The following is a description of a gene set: Mouse Gene Set: GOBP_IMMUNE_EFFECTOR_PROCESS Any process of the immune system that executes a component of an immune response. An effector immune process takes place after its activation. species: Mus musculus, and this is the list of marker genes: H2-M10.2, Kif5b, Dnase1l3, Ighv5-12, Ighv8-8, Ifna12, Ufl1, Klrc3, Ighv1-22 (NCBI Gene Id 780883), Scimp, Mir181b-1, Pnp, BC037156, Fcgr3, Il6, Il1b, Il2rg, Ighv4-1, Abr, Xrcc4, Ccl19, Lgals3, Gab2, Ighv2-9-1, Cd22, Notch2, H2-Q6, Il4ra, Tlr7, Itgam, Ifna14 (interferon alpha 14), Mbl1, Emp2, Gimap3, Ighv11-2, Ccl20, Foxf1, Smad7, H2-Q1, Klre1, H2-T24, Stat6, Ptx3, Cfb (NCBI Gene Id 14962), Cd96, Ighv10-1, Slamf8, Ighv8-2, Cgas, C8g, Trp53, Selenok, Cxcl1, Gkn2, Cdh17, Lgals8, Ncf1, Tmbim6, Slamf6, H2-T22, Stx4a, Pck1, Nkx2-3, Lypd10, Tlr9, Ighv1-81, Sirt1, Casp4, Ighv1-54, Irak4, Lipa, Ffar2, Angpt1, Cd160, Mtor, Nlrp6 (NCBI Gene Id 101613), Sbno2, Cfhr2, H2-Q4, Rag2, H2-Q2, Vamp8, Ighv5-9, Ighv8-9, Crk, Gcnt3, H2-M10.5, Msh2, Ighv14-3, Ighg2c, Tap1, Ighv9-3, Pram1, Ighv5-16, Gata3, Eomes, Mir301, Foxj1, Lyst (NCBI Gene Id 217998), Wdr1, Mrgprb1, Spon2, Syk (spleen tyrosine kinase), Colec11, Pirb, Gzmm, Inava, Klri1, Eif2ak4, Myo1f, Casp1, Cd80, Coro1a, A2m, Shb, Cr2, H2-M11, C1qbp, Ighv2-7, Il13ra2, Ifna5, Cd8a, Nsd2, Bcl3, Appl1 (NCBI Gene Id 97938), Ighv1-4, Btk, Dock11, Ighv8-13, Ighv16-1, Lep, Snx4, Mad2l2 (MAD2 mitotic arrest deficient-like 2), Pik3cb, Ifna7, Prdx1, Ighv1-63, C2, Gm13283, Fosl2, Men1, Ighv1-76, Ighv8-4, Ighv1-5, Nkg7, Cd55b, Hmox1, Tgfb1, St3gal1, Dusp22, Dbh, Trex1, Xbp1, Psen1 (NCBI Gene Id 19164), Traf2, Klk5, Ddrgk1, Il2rb, Clec12b, Irf1, Ighv3-1 (NCBI Gene Id 780803), Klrc2, Mapkapk2, Ighv6-7, Klhl22, F2rl1, Il17f, Gba1, Dlg1, Nfkbid, Ighv5-17, H2-DMa, Trp53bp1, Cd19, Ccl2, Shld3, Jak3, H2-M5 (NCBI Gene Id 630349), Ceacam1, Ighv6-3 (NCBI Gene Id 675759), Nfkbiz, Ifna16, 6030468B19Rik, H2-T5, Ager, Iglc2, Stat5a, Itgb8, Rc3h1, Lyn, Map3k7, Il1r1, Mir873a, Ighe, Raet1d, C1qb, Serpinb9d, Il9, Itfg2, Cd177, Il2, Pgc, Cplx2, Tlr3, Ighv1-47, Foxp3, Ighv1-11, Pla2g5 (phospholipase A2, group V), Cd36, Ighv1-16, Ifnb1, Irak3, Clec7a, C1s2, Klrk1, Ephb6, Fzd5, Vav1, Batf (NCBI Gene Id 54359), Swap70, C8b, Ighv5-12-4, Nectin4, Scnn1b, C9, Tlr4 (NCBI Gene Id 21898), Cd55, Hspd1, Rab44, Hprt1, Rigi, C1qa, Bcl6, Il20rb, Ighv1-82, Plcg2, C7, D6Wsu163e, Enpp3, Hpx, Ighv6-5, F2, Fbxo38, Colec10, Stap1, Jag1, Psen2, Ighv8-5, Cd69, Rorc, H2-D1, Lilrb4a, Rnf168, Clec4d, Wnt5a, Adora2b, Tnf, Ripk3, Cd244a, Il21, Kmt5b, Ighv2-2, Exosc3, Dhx36, Itgb2l, Sema4a, Rora, Igll1, Cd59a, Ptpn22, Tyrobp, Myb, Pik3r6, Ifna1, Cd37, Irf7, Foxp1, Cebpg, Ctsc, Klrb1f, Card9, Rps6, Fer, Pcyox1l, Ulbp1, Ebag9, Kdelr1, Cfhr4, Ighv1-49, Otud5, Rara, Nckap1l, Fcer2a, Tnfsf18, Ighv5-4, Ung, Icosl, Stx11, Plec, Prdx2, Ighv7-1, Ighg2b, Ighv2-3, Pglyrp4, Dusp10, Ifna11, Ighv1-66, Xcl1, Ighv2-6, Gfer, Sash3, Fes, Ighv2-9 (NCBI Gene Id 640046), Tnfsf13, Stxbp1, Mdk, Parp3, Ptgdr, Ndst2, Ighv9-4, Pou2f2, Slc15a4, Tril, Ddx60, Ifnz, Pld2, Hlx, Fcna, 2410137M14Rik, Rab27a, Fcgr1, Ifna9, Serpinb9e, Apoa2, Twist2, Ptpn6, Ahr, Ighv3-3, Ighv1-55, Pou2af1, Dhx58, Tek, Cybc1, Azgp1, Nlrx1, Tnfaip3, Ddx21, Sh2d1b2, Tac4, Ighv3-8 (immunoglobulin heavy variable V3-8), Atg9a, Ighv1-26, Fcgr4, Vpreb3, Gm13276, Laptm5, Ighv1-31, Ube2j1, Zp3r, Cfhr1, Fcmr, Hmces, Calhm6, Enpp1, Ighv1-34, Plxna1, Stard7, H2-Ea, Irf4, Slc11a1, Cd40, Cd180, Klrb1b, Cd1d2, Anxa3, Rtn4, Lcp1, Jagn1, Fcgr2b, Serping1, C1rb, Cfp, Ifng, Crhr1, Crlf2, Il18r1, Apoa1, Ighv2-5, Ace, Tusc2, Zfp683, C1rl (complement component 1, r subcomponent-like), Msh6, Gprc5b, Fcer1g, Ddx1, Ighv2-4, Lat, Bcl10, Nlrp3, Ulbp3, Cd47 (NCBI Gene Id 78539), Traf3ip2, Ndfip1, Mavs (NCBI Gene Id 228607), Trpm4, Fut7 (fucosyltransferase 7, NCBI Gene Id 99110), Ms4a2, Sema6d, Ighv1-84, Krt1, Cd226, Lat2, Pkp3, Elane, Gata1, Paxip1, Ighv1-43, H2-DMb1, Ptk2b, Ccr6, Csf2rb2, Abl1, Ighm, H2-M9, Klrb1, Pms2, Acp5, Pcyt1a, Tirap, Arg1, Hmgb1 (high mobility group box 1), Gpr15lg, Rasgrp4, Tcim, Il13, Ighv3-6, Ifnk, Ywhaz, H2-M2, Iglc3, Gzmb, Fas, Irf5, H2-M3, Rgcc, Vsig4, Cd46, Rac2, Sanbr (NCBI Gene Id 71675), Il27ra, Bst2, Twist1, Ptprc, Inpp5d, Spn, Lig4, Ighv1-67, Lamp1, Ighv14-4, Lilrb4b, Lgals9 (lectin, galactose binding, soluble 9), Il23r, Trim6, Scn11a (sodium channel, voltage-gated, type XI, alpha), Dock2, P2rx7, Igha, Supt6, Ighg3, Ripk2, Gm13277, Epx, Clec2d, Il9r, Cfh, Igf2, Ighv1-15, Clec4g (C-type lectin domain family 4, member g), Atp7a, Crtam, Lbp, Cd24a, Vamp2, Havcr2, Gimap5, Pglyrp1, Evpl, Ighv1-58, Lef1, Prkaa1, H2-M10.4, Phb1, H2-M1, Ighv6-6, H2-M10.3, Cd5l, Il4i1 (NCBI Gene Id 15088), Ighv9-1, Sphk2, Ada, Gm13272, Muc4, Mlh1 (NCBI Gene Id 68687), Il25, Vsir, Cd300a, Serpinb9h, Loxl3, Cxcl5, Rc3h2, Serpinb9, Irf8, Spi1, Shld1, Ighv1-7, Atad5, Pikfyve, Clu, H2-M10.1, Il31ra, Nppa, Lacc1, Ppp3cb, Tmem98, Masp2, Il23a, Zp3, Il12a, Hc, Gm13275, Rif1, Stxbp3 (syntaxin binding protein 3), Tnfrsf4, Gbf1, H2-T15, Susd4, Hcst, Stat4, H2-T13, Klrh1, Unc93b1, Slc22a13, Ffar3 (free fatty acid receptor 3), Ncr3-ps, Cd2, Nod1, Cd27, Rasgrp1, Traf6, Dnajb9, Lfng, Tsc1, Pla2g3, Cbl, Panx1, Rftn1, Cd28, Galnt2, Trem2, C8a, S100a9, Ascl2, Ighv1-78, Serpinb9g, Rbp4, Ep300, Ctsg, Kmt2a, Fcer1a, Myd88, Itm2a, Arrb2, Tap2, Serpinb9b, Lta, Phf14, App, Ighv2-6-8, Clec4e, Lag3, Atg5, Cd70, Tgfb3, Treml4, Kit, Il17a, H2-DMb2, Cr1l, Cd86, Dennd1b, Ighv3-5, Kctd9, Ighv9-2, Ephb2, Zpbp2, Ly9, Sh2d1b1, Tnfrsf14, Ccl3, Stx7, Mr1, Malt1 (NCBI Gene Id 240354), H2-K1, Kmt2e, Slamf1, C1s1, Nectin2 (nectin cell adhesion molecule 2), Cyrib, Kars1, Plcl2 (phospholipase C-like 2), Slc18a2, Prkdc, Cd81, Apbb1ip, Masp1, H2-M10.6 (NCBI Gene Id 399549), C1ra, Mill1, Il13ra1, Ighv1-39, Ighv1-56, Ighv14-1, Rsad2, Klrd1, Was, Lypd11, Ighg1, Csf2rb, Bcr, Litaf, Fgl2, Ighd, Sema7a (sema domain, immunoglobulin domain (Ig), and GPI membrane anchor, (semaphorin) 7A), Gata2, Pi4k2a, H60c, H60b, Rnf19b, Prkce, Cd59b, Milr1, Unc13d, Gzmn, Mrgprx2, Mfng, Tlr2, Ivl, Nos2, Kmt5c, Pomc, Anxa1, Cracr2a, Klrb1a, Dao, Arid5a, Pycard, Siglecg, Ins2, Lgals1, Clcf1, Entpd7, Ighv1-23, Gapt (Grb2-binding adaptor, transmembrane), Gzmc, Snap23, Ins1, Ighv1-42, Itgb2, Ighv1-75, Sftpd (NCBI Gene Id 20390), Ifne, Ccr7, H2-Q10, H2-T3, Zfp35, Iglc1, H2-T23, Pdpk1, Mzb1, Ighv10-3, Slamf9, Pagr1a, Phb2, Prkcd, Ifna4, Ighv7-3, Hspa8, Lrp1, Ighv1-85, Ifnab, Icam1, Gm13271, Pf4, Ighv12-3, Ighv14-2, Ifna15 (NCBI Gene Id 242517), Grn, Prg2, Chga, Pvr, Stat5b (signal transducer and activator of transcription 5B), Brd2, Sh2d1a, Sucnr1, Mir181b-2, Brd4, Mir326, Ccr2, Myo18a, H2-Q7, Ptger4, Ifna2, Aire, Socs5, Ighv1-71, Klk7, Gadd45g, C1qc, Serpinb9c, Itgal, Cfi, C4a, Stat3, Aicda, Ankrd17, Tnfrsf1b, Raet1e, Plekhm2 (pleckstrin homology domain containing, family M (with RUN domain) member 2), Klrc1, Tbk1, Nbn, Crp, Stxbp2, Ighv1-24, Htr2a, Ppl, Aplf, Mif, Il6ra, Pglyrp2, Tbx21, Ptgds, Ighv8-12, Il4, Pglyrp3, Ighv1-61, Axl, Cfd, Pik3r1, Rabgef1, Exo1, Ywhag, Ighv6-4 (NCBI Gene Id 636744), C4bp, Nod2, Clnk, Hk1, Dysf, Ighv1-50, Ighv11-1, Tgfb2, Ifna6, Gfus, Ighv1-72, Mir324, Tnfsf4, Cd274, Rps19, Usp17le, Trem3, Ifna13, Abcc1, Itgb6, Mbl2, Pkn1, Muc19, Arl8b, Trem1 (triggering receptor expressed on myeloid cells 1), Gpr183, Zc3h12a, Nppc, Nmi, Dnase1, Ptafr, Kdm5d, Il7r, C4b, Fadd, Zbtb1 (zinc finger and BTB domain containing 1), Gpi1, C3, B2m, Cadm1, Fgr, Fcrlb, Cd1d1, Exosc6, Ifi35, Myo1g, Tfrc, Ighv8-6, Il5, Relb, Slfn2, Opa1, Adora3, Cebpb, C6, Ercc1, Dpp4, Cd300lb, Tcirg1, Prkcz, Ighv3-4, Klri2, Hfe, Ighv1-62-3 (NCBI Gene Id 668549), Ighv1-53, Appl2, Mpo, Nr4a3, Cuedc2, Pdcd1, Zbtb7b, Grb2, Dll1, Cd40lg, Ighv13-2, Klrb1c, Cd74, Prf1, Ighv1-77, Il33, Cd84, Ighv5-6, Ticam1, Rnf8, Ighv8-11, Il12b, Psg22, Ighv1-64, Grp (NCBI Gene Id 225642), Ighv1-12, Il18rap (NCBI Gene Id 16174), Il18, Fcnb, Serpinb9f, Cx3cr1 (NCBI Gene Id 13051), Ap1g1, Dock10, Shld2, Il10, Ctsh, Ighv1-80, Il27